The following is a description of a gene set: species: Homo sapiens Tyrosine metabolism and related disorders Human Gene Set: WP_TYROSINE_METABOLISM_AND_RELATED_DISORDERS, and this is the list of marker genes: TAT, FAH, HGD (homogentisate 1,2-dioxygenase), HPD, GSTZ1